Given this list of marker genes AHSA2P, STMN3, PGGHG, NEAT1, DFFB, FBXL6, SEC16B, BCL6, CABIN1, STX16, LRRC14, AATBC, ZNF431, NKD2, SLC9A3-AS1, CALHM6, ZNF697, THUMPD3-AS1, SLC20A1, MDM4, MAP3K20, GART, TIMP3, LAMP2, here is a description of the gene set: from publication Sabates-Bellver J, Van der Flier LG, de Palo M, Cattaneo E, Maake C, Rehrauer H, Laczko E, Kurowski MA, Bujnicki JM, Menigatti M, Luz J, Ranalli TV, Gomes V, Pastorelli A, Faggiani R, Anti M, Jiricny J, Clevers H, Marra G (PMID 18171984) A selection of genes whose expression displayed significant positive correlation with size of colorectal adenoma. studied in species Homo sapiens Colorectal cancers are believed to arise predominantly from adenomas. Although these precancerous lesions have been subjected to extensive clinical, pathologic, and molecular analyses, little is currently known about the global gene expression changes accompanying their formation. To characterize the molecular processes underlying the transformation of normal colonic epithelium, we compared the transcriptomes of 32 prospectively collected adenomas with those of normal mucosa from the same individuals. Important differences emerged not only between the expression profiles of normal and adenomatous tissues but also between those of small and large adenomas. A key feature of the transformation process was the remodeling of the Wnt pathway reflected in patent overexpression and underexpression of 78 known components of this signaling cascade. The expression of 19 Wnt targets was closely correlated with clear up-regulation of KIAA1199, whose function is currently unknown. In normal mucosa, KIAA1199 expression was confined to cells in the lower portion of intestinal crypts, where Wnt signaling is physiologically active, but it was markedly increased in all adenomas, where it was expressed in most of the epithelial cells, and in colon cancer cell lines, it was markedly reduced by inactivation of the beta-catenin/T-cell factor(s) transcription complex, the pivotal mediator of Wnt signaling. Our transcriptomic profiles of normal colonic mucosa and colorectal adenomas shed new light on the early stages of colorectal tumorigenesis and identified KIAA1199 as a novel target of the Wnt signaling pathway and a putative marker of colorectal adenomatous transformation. Human Gene Set: SABATES_COLORECTAL_ADENOMA_SIZE_UP